Given this list of marker genes Slc2a2 (NCBI Gene Id 99576), Slc5a10, Slc2a5, Slc2a3, Slc2a7, Slc2a8, Slc2a9, here is a description of the gene set: Mouse Gene Set: GOMF_FRUCTOSE_TRANSMEMBRANE_TRANSPORTER_ACTIVITY species: Mus musculus Enables the transfer of fructose from one side of a membrane to the other. Fructose exists in a open chain form or as a ring compound. D-fructose is the sweetest of the sugars and is found free in a large number of fruits and honey.